Given this list of marker genes TRPM2, RYR1, TRPA1, ITPR3, TPCN1, ITPR2, MCOLN1, MCOLN3, TPCN2, BNIP1 (NCBI Gene Id 662), MCOLN2, TRPV1, RYR3, RYR2, ITPR1, PKD2, here is a description of the gene set: Enables the transmembrane transfer of a calcium ion by a channel that opens when a specific intracellular ligand has been bound by the channel complex or one of its constituent parts. Human Gene Set: GOMF_INTRACELLULARLY_GATED_CALCIUM_CHANNEL_ACTIVITY species: Homo sapiens